Given this list of marker genes Traf5, Ccdc6, Psmb9, Parp14, Psme2, Sp100, B2m, H2-T23 (NCBI Gene Id 15040), Sp110, Apol10b, Dtx3l, Cxcl10, Slfn5 (NCBI Gene Id 327978), Irgm1, Arhgap30, Nampt, Pomp, Zup1, Wars1, Irf9 (NCBI Gene Id 16391), Parp11, Spop, Bcl2l14, Tapbp, Samhd1, Serpina3g, Ankib1, Clec2d (NCBI Gene Id 93694), Tuba1b (NCBI Gene Id 22143), Herc6, Rnf114, Zyx, Ccng2, Pml, Casp4, Ccz1, Ctsc (cathepsin C), Lima1, Mndal, Irgm2, Irf1, Pdia3, Gbp5, Cd274, Atrx, Nudt9, Lpp, Gbp8, Cnn3, Cxcl9, Cfl1, Dnase1l3 (deoxyribonuclease 1-like 3), Il15, Stxbp3, Gbp4, Gbp7, Ubd, Iigp1, 9930111J21Rik2, Ube2l6, Tspo, Parp9, Gnb1, H2-D1, Daxx, Psme1, Insl6, Gbp2, Tmsb10, Xaf1, Fryl, Gbp3, Pnp, Stat1, Tapbpl, Nipa2, Psmb10, Gbp9, Shisa5, Tap2, Nek6, Tap1, Slc22a15, Bst2 (NCBI Gene Id 97478), Ifi203, N4bp1, Selenow, Snx10 (NCBI Gene Id 71982), Slfn8, Il10ra, Ifi27, Calhm6, Plaat3, Ywhah, Txndc17, Akr1a1, Igtp, Socs1, Rabgap1l, Irf8, Fbrsl1, App, Il21r, Pafah1b3, Ccnd2, Psma3, Ifi27l2a, Isg15, Fbxw17, Plin2, Serpinb9, Nlrc5, Ktn1, Rnf213, Usp12, Myl12a, Stat2, Tpm3, Selplg, Mpeg1, Trafd1, Oasl2, Selenot, Irf7, Socs2, Marchf5, Tuba1a, H2-DMa, Atr, Ahnak, Vim, Tmbim6, Serpinb1a, Tpm4, Dbnl, Nfya, Cd1d1, Trps1, Bcl2l11, Ifi47, Rnf19b, Zbp1, Ciita, Glipr2, Wdr1, Atp6v0a1, Txn1, Hsf2, Sdc3, here is a description of the gene set: Cytokines mediate cell-cell communication in the immune system and represent important therapeutic targets. A myriad of studies have highlighted their central role in immune function, yet we lack a global view of the cellular responses of each immune cell type to each cytokine. To address this gap, the authors created the Immune Dictionary, a compendium of single-cell transcriptomic profiles of more than 17 immune cell types in response to each of 86 cytokines (>1,400 cytokine-cell type combinations) in mouse lymph nodes in vivo. A cytokine-centric view of the dictionary revealed that most cytokines induce highly cell-type-specific responses. For example, the inflammatory cytokine interleukin-1β induces distinct gene programmes in almost every cell type. A cell-type-centric view of the dictionary identified more than 66 cytokine-driven cellular polarization states across immune cell types, including previously uncharacterized states such as an interleukin-18-induced polyfunctional natural killer cell state. Genes positively differentially expressed in cell type: MigDC (migratory dendritic cell) upon treatment with cytokine: IFN-γ in mouse lymph nodes in vivo. Mouse Gene Set: CUI_MIGDC_IFNG_RESPONSE_UP studied in species Mus musculus from publication Cui A, Huang T, Li S, Ma A, Pérez JL, Sander C, Keskin DB, Wu CJ, Fraenkel E, Hacohen N (PMID 38057668)